The following is a description of a gene set: Distance between subnasale and pronasale more than two standard deviations above the mean, or alternatively, an apparently increased anterior protrusion of the nasal tip. Prominent nose Human Gene Set: HP_PROMINENT_NOSE studied in species Homo sapiens, and this is the list of marker genes: APC2, EXTL3, CDK19, NHS, PCNT, AP1S2, SMC5, FOXP2, SRCAP, RLIM, QRICH1, UNC80, BPTF, CUL4B, COG3, ZNF699, MINPP1, EIF4A3, EMG1, SLF2, TAF6, CTSK, EP300, ITPR1, FHL1, PMM2, FILIP1, CENPE, HNRNPC, ERCC6, WNK3, UFC1, SPOP, PSMB8, STIL, FBXL3, SOX6, ACTB, TMEM94, MAN1B1, MED12, INTU, SNRPN, PUM1, CDK5RAP2, PLAAT3, FGF3, GPC4, MBD5 (NCBI Gene Id 55777), TAF4, CENPT, ERCC2, LIG4, PLK4, NIN, ERCC8, WARS1, ADAT3, EXOSC5, SPART, KAT6B, STIM1, NSUN2, BCL11B, RUSC2, DYNC1I2, CEP120, TTC5, AARS1, PSMD12, RBBP8, ASPH, GNB2, TTI2 (NCBI Gene Id 80185), ATR, POC1A, WDR73, CHD3, PGM2L1, BLM, PEX3, GJA5, ACTG1, PLAGL1, SMG8, FBXO11, AP4S1, COG5, CLTCL1, GMPPA, ZNF668, METTL5, PDE4D, EBF3, H4C5, NFIX, OPHN1, RNU4ATAC, CREBBP, PEX19, ASH1L, STAG2, USP9X, NONO, HYMAI, ITGA3, ACER3, ZFX, LMBR1, NBN, GJA8, DENND5A